Given this list of marker genes Adrb2, Spast, Cfl2, Gba1, Actn2, Eif5a2, Igtp, Cracd, Sema5a, Nes, Tnf, Igf1r, Calcoco2, Setx, Htr1a, Cfl1, Tom1, Vil1, Oga, Katnb1, Carmil1, Insr, Jmjd4, Irgm2 (NCBI Gene Id 54396), Pdxp, Fyco1, Plek, Dstn, Bnip3, Trpv4, Stmn2, Wdr1, Clec16a, Carmil2, Smcr8, Irgm1, Wnk1 (WNK lysine deficient protein kinase 1), F2rl1, Eif5a, Aurkb, here is a description of the gene set: Mouse Gene Set: GOBP_POSITIVE_REGULATION_OF_PROTEIN_CONTAINING_COMPLEX_DISASSEMBLY Any process that activates or increases the frequency, rate or extent of protein complex disassembly, the disaggregation of a protein complex into its constituent components. species: Mus musculus